The following is a description of a gene set: part of: Innate Immune System This event has been computationally inferred from an event that has been demonstrated in another species.<p>The inference is based on the homology mapping from PANTHER. Briefly, reactions for which all involved PhysicalEntities (in input, output and catalyst) have a mapped orthologue/paralogue (for complexes at least 75% of components must have a mapping) are inferred to the other species. electronically inferred by orthology from the curated human pathway studied in species Mus musculus Reactome Pathway: DDX58/IFIH1-mediated induction of interferon-alpha/beta, and this is the list of marker genes: Irf7, Rela, S100b, Ep300, Rigi, Rps27a, Ubb (ubiquitin B), Ikbkb, Mavs, Hmgb1, Irf3, Nkiras1, Nfkbib, Tnfaip3, Nlrx1, Ager, Nfkb1 (nuclear factor of kappa light polypeptide gene enhancer in B cells 1, p105), Cyld, Nfkbia, Nfkb2